The following is a description of a gene set: Genes down-regulated in comparison of CD8 T cells at 0 h versus those at 48 h after stimulation with IL12. Differentiation of naive CD8 T cells into cytotoxic effector cells requires three distinct signals- antigen (signal 1), costimulation -B7-1 (signal 2) and cytokine, either interleukin-12 or interferon-a/b (signal 3). Interaction of naive CD8 T cells with antigen and B7-1 programs cell division and proliferation whereas the presence of cytokines- IL-12 or IFNa/b promote survival, differentiation and memory establishment. In the absence of signal 3, the cells interacting with antigen/B7-1 undergo tolerance induction. The objective of this study was to elucidate the mechanisms how the provision of signal 3 promotes differentiation and averts tolerance induction in CD8 T cells. Trichostatin A is a pharmacological agent that inhibits histone deacetylase activity, hence regulating chromatin structure and gene expression and differentiation in many cell types. Gene signature profiles of IL-12, IFNa/b and trichostatin A stimulated cells were compared to elucidate the molecular mechanisms of gene regulation. Oligonucleotide microarray analysis is carried out to determine the extent and molecular nature of the CD8 T cell differentiation program induced by IL-12 or IFNa/b in concert with antigen and B7-1 signal. from publication Agarwal P, Raghavan A, Nandiwada SL, Curtsinger JM, Bohjanen PR, Mueller DL, Mescher MF (PMID 19592655) Human Gene Set: GSE15930_NAIVE_VS_48H_IN_VITRO_STIM_IL12_CD8_TCELL_DN studied in species Homo sapiens, and this is the list of marker genes: CINP, RPF2, BLVRA, EFTUD2, TAF11, MTCH2, CDCA4, UBE2M, HTATIP2, SLC30A4, NUP93, SQLE, POLA1, ALCAM, TIMM8A, PRELID1, THOP1, PDAP1, HPF1, NDUFA8, C1orf174, DPP3, PDIA6, NOP16, HOPX, PSMA1, CDC6, COQ7, MDFIC, CLCN3, SELENOH, SSR2, TIMM13, FASLG, CPOX, NCAPH, CCNC, NELFCD, DRG1, PSMD1, NDUFS5, ETF1, PHB1, CRABP2, ZNHIT1, LAMTOR5, EXOSC7 (NCBI Gene Id 23016), NELFE, NCBP2, PLRG1 (NCBI Gene Id 5356), MTHFD2, BSG, PSMB5, GABARAPL1, ALKBH5 (alkB homolog 5, RNA demethylase), MRPL15, TARS1, BUB1, IRF4, MTX2, TMEM223, HDLBP, GCSH, NEK2, MOGS, PMPCB, PPP1R7, LONP1, COA3, IPO11, MESD, SLC25A17, MAD2L1 (mitotic arrest deficient 2 like 1), PPA1, DDX1, FXN, GNPAT, CCNG1, COPS5 (NCBI Gene Id 10987), FUBP1 (NCBI Gene Id 8880), PFKL, DDT, UXS1, GTF2E2, HNRNPLL, MZT2B, LSM2, CCND3, TTK, HMGCS1, PCYT2, SSBP1, LMNB1, MTMR9, ECPAS, NUP85, UBE2L3, S100A6, SAR1B, FAM98A, DPY30, IPO7, SIVA1, VRK1, SKIC8, MT1E, NDFIP2, PLPBP, UQCR11, GK, TIPIN (TIMELESS interacting protein), AIMP2, ITPA, FOXK2, SSNA1, TARDBP, EIF2B5, TFDP1, RRM1, PIGF, RUVBL2, POLR2I, LIG1, GUSB, PGM1, CTPS1, ZRANB2, RBM10, PRDX2, CDK2, TRIM41, ALDOA (NCBI Gene Id 226), PHTF2, CUL2, HMGCR, PLSCR1, SNRNP40, MRPS10, CDS2, MRPS7, DTL, COPS7A, BCAT1, IFRD2 (interferon related developmental regulator 2), NASP, POLD2, NHP2, ZW10, EXO1, CDC7, APBA3, NUP62, SMC2, MCM7, RER1, RBMXL1, KPNA2, ERG28, PMM1, DESI1, MRPL36, RRM2 (ribonucleotide reductase regulatory subunit M2), CCT6A, MRPL44 (NCBI Gene Id 65080), GPD2, MARCKSL1, LACTB2, PGRMC1, FARSA, VPS29, GPN2, TIMM17B, SH3BGRL, BNIP1, MRE11, ARL1, TOMM40, AGPAT3, LMAN1, UBE2S, LSM1, RNFT1 (NCBI Gene Id 51136), CENPC (centromere protein C), SEC23B, ARL3, CLIC4, KPNA3, ATP5IF1, CFAP20, DNMT1, AHCY, LGALS1, ECT2, CAPG, XPOT, PRDX4 (NCBI Gene Id 82852), ALAS1, CDC16, MRPL11, NUSAP1